The following is a description of a gene set: Pathway Definition from KEGG: Trp -- TPH1/2 >> DDC -> Serotonin -- MAO -> 5-HIAL Serotonin metabolism. Pathway ID: N01551. Pathway type: Reference. Pathway class: nt06028 Dopamine and serotonin metabolism. Human Gene Set: KEGG_MEDICUS_REFERENCE_SEROTONIN_METABOLISM species: Homo sapiens, and this is the list of marker genes: MAOB, MAOA, TPH2, TPH1, DDC